Given this list of marker genes GNB1, GNB2, ARHGEF6, GNB5, GNGT2, GNGT1, GNG11, GNG10, GNB4, GNG8, GNG2, GNG4, GNG3, GNB3, GNG12, CDC42, GNG5, GNG13, GNG7, PAK1, here is a description of the gene set: Reactome Pathway: G beta:gamma signalling through CDC42 species: Homo sapiens part of: G-protein beta:gamma signalling G-Protein Coupled Receptors (GPCR) sense extracellular signals and activate different Guanine nucleotide binding proteins (G-proteins) that have alpha, beta and gamma subunits. Upon activation, the alpha subunit of G-proteins dissociates from beta-gamma and the both are then free to regulate downstream effectors. Serine/threonine-protein kinase PAK 1 binds with Rho guanine nucleotide exchange factor 6 (ARHGEF6, PIX-Alpha) in the cytosol and is subsequently translocated by the G-protein beta-gamma complex to the plasma membrane. Here, ARHGEF6 activates Cell division control protein 42 homolog (CDC42) by acting as a GEF. Once active, CDC42 can facilitate the activation of PAK1. CDC42 is known to be involved in epithelial cell polarization processes.